The following is a description of a gene set: species: Mus musculus Genes selectively expressed by postmitotic projection neurons beginning in the intermediate zone, in most cases extending into the cortical plate of embryonic day 14.5 mouse cortex. from publication Bedogni F, Hevner RF (PMID 34321999) Mouse Gene Set: HEVNER_INTERMEDIATE_ZONE_AND_UP_POSTMITOTIC_PROJECTION_NEURONS, and this is the list of marker genes: Edil3, Kcnn2, Tmem177, Cttnbp2, Sema6d, Hdac5, Cog1, Abcc8, Kcnn3, Rnd2, Epha3, Gria2, Neurod2, Flrt1, Nuak1, Efnb2, Inf2, Clstn2, Thra, Robo2, Ppp2r1b, Scg3, Ttc28, Cacnb3, Cyria, Nav2 (NCBI Gene Id 78286), Mvb12b, Itm2b, Setd6, Sgpl1, Nfib, Usp46, Cap2, Chst15, Ptpn4, Igfbpl1, Cntn2, Tiam2, Slc17a7, Dpy19l1, Plxna4, Zbtb18, Itpk1, Id2, Cacna2d1, Bhlhe22, Tbr1, Cnr1, Prdm8, Fhod3, Tmem74, Nos1, Nrp1, Ntng2, Cemip, Dennd11